Given this list of marker genes Rtn4rl2, Sema6d, Ppp3ca, Marchf7, Sema3f, Ywhah, Ryk, Vim, Tlx2, Rab3ip, Plxna3, Gak, Itm2c, Tbc1d30, Trak2, Map2, Prkcd, Apoe, Tesk1, Inpp5f, Arhgap4, Yap1, Map4k4, Ccr5, Paqr3, Arhgap24, Ptk2, Lrrk2, Mdm2, Ulk2, Actr3, Plxnb3, Ulk1, Dguok, Ngef, Dtnbp1, Syngap1, Epha7, Kremen1, Tsc2, Rtn4r, Arhgap44, Trim46, Lgals1, Bcl11a, Id1, Zfp365, Coro1b, Luzp1, Rtn4, Dnm2, Ptpn9, Prkcsh, Fstl4, Inpp5j, Xylt1, Lrig2, Lrp4, Adam17, Cdk10, Lima1, Dip2b, Ntm, Spry2, Tnr, Tacstd2, Nrxn1, Ccp110, Sema4f, Fyn (Fyn proto-oncogene), Gdi2, Ptprs, Draxin, Capzb, Thy1, Mphosph9, Nfatc4 (nuclear factor of activated T cells, cytoplasmic, calcineurin dependent 4), Slit2, Carm1, Cspg4, Tchp, Amigo3, Wnt3, Adcy6, Trpv4, Rtca, Prnp, Rapgef2, Cyth2, Efnb3, Dpysl3, Gfap, Dennd5a, Nrp1, Crmp1, Mgarp, Wnt5a, Zfp296, Cd38, Tbx6, Sema5a, Odf2l, Dkk1, Rhoa, Ifrd1, H2-D1, Prag1, Efna1, Nr2f1 (NCBI Gene Id 13865), Ptprg, Hdac2, Cfl1, Mt3, Kank1, Minar1, Mak (NCBI Gene Id 17152), Dab2, H2-K1, Dync1i2, Sema3a, Mylip, Stap1, Ttc3 (tetratricopeptide repeat domain 3), Kif24, Gsk3a (glycogen synthase kinase 3 alpha), Ube3a, Nlgn1, Wnt3a, Fat3, Evl, Neu4, Mbp, Pten, Dleu2, Tbc1d7 (NCBI Gene Id 67046), Itga3, Hdac6, Trim32, B2m, Rufy3, Lrp1, Ptprz1, Dnm3, Gfi1, Cdh1, Dab1, Wdr44, Stx1b, Ptprf, Cep97, Tsc1, Grin2b, Lpar1, Limk2, Cdkl3, Rtn4rl1, Cbfa2t2, Katna1, Slit1 (NCBI Gene Id 226119), Fgf13, Diaph1, Mag, Acp4, Nlgn3, Dpysl5, Thoc2, Inppl1, Gdi1, Gorasp1, Stmn2, Rit2, Snapin, Neo1, Ptpn1, Ngfr, Ntn1, Gsk3b, Pmp22, D130043K22Rik, Itgb1, Rap1gap2, Efemp1, Rab29, Glce, Cib1, Trpc5, Evi5l, Arpin, Efnb2, Sema3g, Pafah1b1, Spart, Rnf6, Fkbp4, Cers2, Abi3, Ephb2, Rgma, Psen1, Spock1 (sparc/osteonectin, cwcv and kazal-like domains proteoglycan 1), Epha3, Cit, Cdk5, Arf6, Pfn2, Bag5, Hes1 (NCBI Gene Id 15205), Akt1, Epha4, Il15ra, Rap1gap, Ccl21a, Flna, Hrg, Runx1t1, Sema6c, Tsku, Trpc6, Diaph2 (NCBI Gene Id 54004), here is a description of the gene set: Mouse Gene Set: GOBP_NEGATIVE_REGULATION_OF_CELL_PROJECTION_ORGANIZATION Any process that stops, prevents, or reduces the frequency, rate or extent of a process involved in the formation, arrangement of constituent parts, or disassembly of cell projections. species: Mus musculus